Given this list of marker genes BDNF, RCOR1, HTT, HDAC2, REST, HDAC1, SIN3A, here is a description of the gene set: studied in species Homo sapiens Mutation-caused aberrant Htt to REST-mediated transcriptional repression. Pathway ID: N00980. Pathway type: Variant. Pathway class: nt06461 Huntington disease. Human Gene Set: KEGG_MEDICUS_VARIANT_MUTATION_CAUSED_ABERRANT_HTT_TO_REST_MEDIATED_TRANSCRIPTIONAL_REPRESSION Pathway Definition from KEGG: HTT* // REST == (SIN3A+RCOR1+(HDAC1,HDAC2)) =| BDNF